Given this list of marker genes APAF1, GZMA, UBAC1, RSPRY1, PRPF3, G0S2 (NCBI Gene Id 50486), TJP2, MXD1, RAMP2, RBM28, SMPD3, GJC2, GOT2, ASPA, PDHA2, TOM1L1 (NCBI Gene Id 10040), DAPK3, GDPD2, RPA1, MAML2, AKT3, TBRG1, CHAD, UQCR11, CCN3 (cellular communication network factor 3), POPDC3, NOG, ALDH7A1, CABP2, EFHD1, C8orf33, ATOX1, GNB5, KCNE4, GOSR2, ENSG00000285566, TEX11, SEPHS1, EDEM1, CAPN15, GP9, GSPT2, WDR83, SDHD, GNG12, GPR87, NID2, FKBP5, FERMT2, TIMM50, MBTPS1, EBI3, POLR3K, ENPP4 (ectonucleotide pyrophosphatase/phosphodiesterase 4), COL18A1, SLC44A3, IL4R (interleukin 4 receptor), HMGXB3, SORCS2, CCDC47, TRAPPC12, KIN, TNNI3, ALDH1A2, ICAM5, MYL10, WEE1 (NCBI Gene Id 7465), TENM1, CERS5, TIMM13, SYT10, PSMD9, MFSD10, TRIO, FMNL3, P2RX4, NAT2, IGFBP5, WDR46, ERMP1, CCDC91, CD8A, FOS, BCL2L10, MFSD3, ENPP5, PITX2 (NCBI Gene Id 5308), LBR (lamin B receptor), ERP29, ARHGAP17, SIT1 (NCBI Gene Id 27240), ZFP91, TSPAN31, SLX9, ZDHHC12, PYROXD1, LAMB1, LZTFL1, TXNL4A, PDE6G, DGKE, UCK1, PRKRA, KLK10, IFT57, SMC1B, NFAM1, ADAM19, ALOX15B, HIC1, NOL3, AKT2, FAU, ADGRL1 (NCBI Gene Id 79732), HRH4, GASK1B, CTNS, P2RX7, GDNF, PGAP4, MLXIP, CDH2, HBE1 (NCBI Gene Id 3046), FBH1, FLT1, SRSF5, ZSCAN5B, POU5F1, GABPA, TMEM87A, ITPKB, ZDHHC3, AGBL3, NSMCE1, PPARGC1B, PCOLCE2, LHX1, NRL, PGM2, HECTD1, BRDT, NPTX1, TMEM14C, TRIB2, SERPINA12, RAI14, DUSP14, CEP104, KRTAP21-1, LMNB2, NSMCE3, CHFR, ZNF418, ZFP92, RNPEP, PEX11B, LAMP1, ITGA4 (NCBI Gene Id 3676), SPATA4, WNT5A, PTGER1, SLC9B2, NENF, SFT2D2, PAFAH2, DBNDD1, ELF5, VIRMA, STAG1, CUL4B, ST6GALNAC1, HGSNAT, CALB1, NME4, CXCL17, HK2, GABRG3 (NCBI Gene Id 653227), TM4SF20, STRA6, MAGIX (MAGI family member, X-linked), RETN, CEP131, SMC5, SOX9, ALG9, PHAX, MTARC2, KLF3 (NCBI Gene Id 51274), BEX3, SEMA3F, NKX3-2, DCAKD, LGI1, FCER1A, TIMM29, FCGRT, GIMAP4, BLOC1S5, ATP6V0A2, SAP30BP (SAP30 binding protein), here is a description of the gene set: studied in species Homo sapiens CD8+ T cells play a crucial role in the clearance of intracellular pathogens through the generation of cytotoxic effector cells that eliminate infected cells and long-lived memory cells that provide enhanced protection against reinfection. We have previously shown that the inhibitor of E protein transcription factors, Id2, is necessary for accumulation of effector and memory CD8+ T cells during infection. Here we show that CD8+ T cells lacking Id2 did not generate a robust terminally-differentiated KLRG1hi effector population, but displayed a cell-surface phenotype and cytokine profile consistent with memory precursors, raising the question as to whether loss of Id2 impairs the differentiation and/or survival of effector-memory cells. We found that deletion of Bim rescued Id2-deficient CD8+ cell survival during infection. However, the dramatic reduction in KLRG1hi cells caused by loss of Id2 remained in the absence of Bim, such that Id2/Bim double-deficient cells form an exclusively KLRG1loCD127hi memory precursor population. Thus we describe a role for Id2 in both the survival and differentation of normal CD8+ effector and memory populations. Genes down-regulated in KLRG1 low CD8 T effector cells during infection: wildtype versus BCL2L11 knockout. Human Gene Set: GSE41978_WT_VS_BIM_KO_KLRG1_LOW_EFFECTOR_CD8_TCELL_DN from publication Knell J, Best JA, Lind NA, Yang E, D'Cruz LM, Goldrath AW (PMID 23325888)